Given this list of marker genes Fbxo41, Phc2, Hoxd1, Tmem186, Fat1, Thsd7a, Agap1, Gnas, Adra2c, Kif3a (kinesin family member 3A), Fndc5, Sh3pxd2a, Hectd4, Ppp2r2d, Rnf187, Eif4enif1, Acnat1, Plcb2, Tafa3, Pacsin3, Camta1, Rfng, Parp10, Kctd14, Rab11fip3, Arhgef1, Slc33a1, Cd86, Lcn4, Aak1, Myo9b, Dand5, Gdap1l1, Clptm1, Cpped1, Vsx2, Ovol1, Pdzd7, Nlgn2, Map4, Akt3, Magea9, Puf60, Ptpn9, Glrp1, Mgst2, Ctbp2, Psd3, Rfx2, Atosa, Srgap1, Ttl, Syt9, Med13, Ankrd13c, Plekhg2, C1qtnf1, Vmn2r42, Tmod2, Rasd2, Trpm2, Rhod, Ccdc60, Ambra1, Cabyr, Armcx4, Cyth3, Usp1, Eif4e2, Csf1, here is a description of the gene set: studied in species Mus musculus Mouse Gene Set: MIR_1956 from publication Chen Y, Wang X (PMID 31504780) Genes predicted to be targets of miRBase v22 microRNA mmu_miR_1956 in miRDB v6.0 with MirTarget v4 prediction scores > 80 (high confidence targets).